Given this list of marker genes CHSY1, PTGER3, RABIF, AIMP2 (NCBI Gene Id 7965), CCND3, NDST1, SS18L2, TLCD1, PLP2, IMPA1, BATF3, CSF2RB, OLIG2, KLF6, ENTPD1-AS1, CD69, TRMT6, CD40LG, ATP4A, PALS2, GNE, MIR3142HG, EBNA1BP2, IL6, MSH2, RPP38, GRPEL1, FOSL2, PUM3, ZNF664, DNAAF5, TRNT1, RBM18, TET3, PKP4, RPP30, NOL8, PPP1R15B, ZNF593, MAPKAPK5, ADCY3, SETD3, CDC6, BAG1, DNAJA3, LRFN4, IDI2, CRLS1, ZNF280B, RPF2, RHEBL1, FNDC3B, TNFRSF1B, LDHA, TAF1A, MCM6, GNPNAT1, SKI, GAGE1, IQCG, CHCHD4, SURF6, IVNS1ABP, CDCA4, BATF, MFSD2A, CEBPD, EEF1E1, MRM2, ZDHHC9, SPEN, ZNF584, NANP, SRSF2, ZC3HAV1L (zinc finger CCCH-type containing, antiviral 1 like), CLIC6, RAD51, WDR46, EGLN1, CBFB (core-binding factor subunit beta), GINS3, AMMECR1L, SRSF7, TTC4, WDR4, FBXO30, USP36 (NCBI Gene Id 80160), HSPD1, TSEN2 (tRNA splicing endonuclease subunit 2), INHBE, HNRNPAB, UBE2N, ALG8, SFT2D1, TOP6BL, MTHFD1L, KIF2A, MCRIP2, DDIAS, TRIB3, CDC123, PLPP1, ERICH1, OTUD4, HNRNPDL, IL27RA, CNBP, WRNIP1, POLR1G, ATG101, BRI3BP, SNX25, ACTR3, QTRT2 (NCBI Gene Id 79691), IMP4 (IMP U3 small nucleolar ribonucleoprotein 4), EPOP, VEGFA, FARSB, FLVCR1, TAL1, WARS1, DCAF1, LYSMD2, TRAPPC4, EPHB2, PRKDC, DKC1, RABGGTB, CD55, RFC3, CPSF7, SERPINB9, MYCBP (NCBI Gene Id 26292), NOP16, BCS1L, ZNF473, SRI, DPY19L3, HILPDA, HEY1 (NCBI Gene Id 23462), IL19 (NCBI Gene Id 29949), PDK1, GNL3, TLCD3A, PACC1, ADO, RPS19BP1, COLGALT1, CHD1L, IL17RB, ZNF200, NCL, EIF3J, GTF2A2, POLR1F, JUND, RRM2, PMM2, PES1, HSPA5, POMGNT1, RERE, TNFSF11, GRPEL2, ING5, CLIP4, SLC43A3, MAP3K21, RPP40, NPB, CDK5R1, MRPS6, OTUD5, TIMM13, GPR55, NAA20, NIP7, FEM1B, PNMA8A, CCND2 (NCBI Gene Id 894), SHLD2, NANS, MLX, ETS2, PDSS1, POLRMT, POLR3K, DDX10, PPAN, METTL1, NDUFAF6, BYSL, DHX33 (NCBI Gene Id 56919), SLC25A17, GZMB, RRP7A (NCBI Gene Id 27341), SPIN4, SLC2A3 (NCBI Gene Id 94827), ADORA2B, here is a description of the gene set: Human Gene Set: GSE46606_UNSTIM_VS_CD40L_IL2_IL5_DAY3_STIMULATED_BCELL_DN from publication Ochiai K, Maienschein-Cline M, Simonetti G, Chen J, Rosenthal R, Brink R, Chong AS, Klein U, Dinner AR, Singh H, Sciammas R (PMID 23684984) Genes down-regulated in at day 0 B cell wildtype versus CD40L and IL-2 IL-4 IL-5 stimulated at day 3 B cell wildtype. Temporal analysis of B cell activation in vitro using CD40L and IL-2/4/5 cytokines in wild type Irf4+/+ B cells or in mutant Irf4-/- B cells harboring a tet-inducible allele of Irf4. IRF4 expression was restored, or not, in the Irf4-/- background by culturing in the presence of low or high concentrations of doxycycline. The results provide insight in the role of IRF4 expression levels in coordinating different programs of B cell differentiation. studied in species Homo sapiens